Given this list of marker genes SELENOK, TWIST1, MCOLN2, TRPV4, HMGB1, SYK, CLEC7A, AGER, IL1B, OAS1, OAS3, LGALS9, ADIPOQ, MIR92A1, here is a description of the gene set: species: Homo sapiens Any process that activates or increases the frequency, rate, or extent of production of monocyte chemotactic protein-1. Human Gene Set: GOBP_POSITIVE_REGULATION_OF_MONOCYTE_CHEMOTACTIC_PROTEIN_1_PRODUCTION